The following is a description of a gene set: The chemical reactions and pathways resulting in the breakdown of purine deoxyribonucleotide, a compound consisting of deoxyribonucleoside (a purine base linked to a deoxyribose sugar) esterified with a phosphate group at either the 3' or 5'-hydroxyl group of the sugar. Mouse Gene Set: GOBP_PURINE_DEOXYRIBONUCLEOTIDE_CATABOLIC_PROCESS species: Mus musculus, and this is the list of marker genes: Urad, Xdh, Nt5c1a, Urah, Nudt16, Samhd1, Nudt15 (nudix hydrolase 15), Gda, Nt5c2, Pnp, Dnph1, Nudt18, Nt5c, Uox, Ada